The following is a description of a gene set: Mouse Gene Set: GOBP_RESPONSE_TO_ACTINOMYCIN_D species: Mus musculus Any process that results in a change in state or activity of a cell or an organism (in terms of movement, secretion, enzyme production, gene expression, etc.) as a result of an actinomycin D stimulus., and this is the list of marker genes: Gfer, Trp53, Mdm2, Kat7, Rpl23